Given this list of marker genes ENPP1, FLNA, KRT5, IDH1, PSENEN, POGLUT1 (protein O-glucosyltransferase 1), KIT, ABCC6, POFUT1, here is a description of the gene set: Human Gene Set: HP_HYPERPIGMENTED_PAPULE studied in species Homo sapiens A papule (circumscribed, solid elevation of skin with no visible fluid, varying in size from a pinhead to less than 10mm in diameter at the widest point) that exhibits increased pigmentation (is darker) compared to the surrounding skin. Hyperpigmented papule